The following is a description of a gene set: Genes predicted to be targets of miRBase v22 microRNA mmu_miR_367_3p in miRDB v6.0 with MirTarget v4 prediction scores > 80 (high confidence targets). from publication Chen Y, Wang X (PMID 31504780) species: Mus musculus Mouse Gene Set: MIR_367_3P, and this is the list of marker genes: Adam19, Lhfpl2, Tbc1d12, Wrnip1, Ccnjl, Nlgn1, Tob2, Tulp4, Ranbp9, Osbpl8, Pcdh9, Trim36, Golga1, Ugp2, Ankrd28, Fzd10, Flvcr2, Rbpj, Appl1, Bcat2, Jmy, Tgif1, Zfp827, Ikzf2, Kcna1, Hps6 (HPS6, biogenesis of lysosomal organelles complex 2 subunit 3), Gpc6, Dynlt3, Dmxl1, Hivep1, Armc1, B230219D22Rik, Wdfy3, Robo2, Adamtsl1, Grip2, Man2a1, Isca1, Ubash3b, Dpp10, Prkar1a, Cog3, P2ry13, Cux1, Hand2, Grhl1 (NCBI Gene Id 195733), Nova1, Cic, Tob1, Atxn1, Ube2z, Dkk3, Fhl2, Rsbn1, Slc24a3, Pcdh7, Greb1l, Fhip2a, Ptprk, Rhpn2, Arid1b, Btg2, Sertad3, Atp7a, Grp, Ewsr1, Fbxw7, Zfc3h1, Gnpda2, Npc1, Ppp1r37, Eomes, Glra1, Pitpna, Dnaaf9, Itgav, Rassf3, Otud4, Rbm27, Col27a1, Pkdcc, Fnip2, Col1a2, Pitpnm2, Ptpro, Pdzd2, Adcy3, Acrv1, Nox4, Dus2, Pten, Nsmf, Fnip1, 1810055G02Rik, Rnf4, Golga4, Pik3cb, Map2k4 (NCBI Gene Id 26398), Ric1, Kmt5b, Ddhd1, Sgpp1, Bcl11a, Gpr158, Klf2, Chia1, Hipk3, Ppcs, Plekhm1, Bmpr2, Golga7, Trim65, Zdhhc5, Itpr1, Usp36, Exoc5, Xrn1, Ttc9, Rev3l, Gramd2b, Nufip2, Lats2, Ccnc, Cep41, Phlpp2, Glyr1, Ddx3y, Snap29, Myt1l, Nsmaf (NCBI Gene Id 93775), Mycbp2, Cpeb4, Adam10, Galnt14, Scn8a, Srpra, Prrc2b, Gdf11, Pcolce2, Sfxn1, Cadm2, Pik3r3, Tmem184b (NCBI Gene Id 223693), Fam20c, Sox11, G3bp2, Daam1, Zfyve21, Glce, Evx2 (NCBI Gene Id 14029), Abhd13, Adam23, Ptar1, Snapc1, Ago3, Cpeb3, Slc6a1, Phtf2, Insig1, Bahcc1, Bsdc1, Sh3pxd2a, Itga8, Atrx, Pnisr, Pip5k1c, Arf1, Rab3c, Gfpt2, Fmn2, Gla, Myo5a (NCBI Gene Id 57374), Aggf1 (angiogenic factor with G patch and FHA domains 1), Bltp1, Hnf1b, Foxn2, Avl9, Cdk16, Adamtsl3, Iqgap2, Ppp1r12c, Lpin1, Tcf21, Gsta2, Klf4, Bcl11b, Elk4, Snx13, Rab8b, Cpeb2, Trak2, Gata2, Tsc1, Slc17a6, Slx4, Fry (FRY microtubule binding protein), Rbpms2, Med19, Lmbr1l, Fancm, Pla2g10, Tent4a, Klhl14, Tbl1xr1, Dock9, Sim2, Evi5, Per2, Asxl2, Nol4l, Csmd3, Cnep1r1, Gm5148, Kifap3, Gpr180, Itprid2, Fnbp4, Morc3, Braf, Fcho2, Pcgf3, Zfp521, Nsd3, Synj1, Slc25a36, Jarid2, Tmem229a, Ergic2, Luzp1, Ddx3x, Strn3, Nckap5, D16Ertd472e, Map1b (NCBI Gene Id 268696), Atxn3, Nefm, Syn2, A830018L16Rik, Ptger4, Cyp2d22, Mboat2, Gid4, Fli1, Fosl2, Aida, Rad21, Baz2b, Spryd4, B3galt2, Itga6, Gata6, Klhl29, Tef, Tmem87a, Slco6c1, Pp2d1, Dtx2, Prkar2b, Mast4, Paxbp1, Ankrd44, Wwp2, Xylt2, Dennd4b (DENN domain containing 4B), Ssbp2, Zeb2, Cldn11 (NCBI Gene Id 18417), Herc2, Itga5, Dcaf6 (DDB1 and CUL4 associated factor 6), Ddc, Dnajb9, Edem1, Dennd1b, Wasl, Rnf38, Rgs17, Cd69, Ldlrad4, Bcl2l11, Nfyc, Slc12a5, Tpcn1, Myo1b, Fkbp1a, Trio, Fbn1, Herpud2 (NCBI Gene Id 80517), Stk39, Mia3, Dsc2, Mpp1, Gnaq, Usp28, Sgk3, Rfx1, Slc25a32, Arrdc4, Peak1, Ube2w, Arrdc3, P3h3, Gsta5, Hecw1, Zfp287, Kat2b (K(lysine) acetyltransferase 2B), Robo1, Rgs3, Cdca7l, Pcdh11x, Slc38a2, Mapk8